The following is a description of a gene set: from publication Chaussabel D, Semnani RT, McDowell MA, Sacks D, Sher A, Nutman TB (PMID 12663451) studied in species Homo sapiens Human Gene Set: GSE360_L_MAJOR_VS_T_GONDII_MAC_DN Monocyte-derived dendritic cells (DC) and macrophages (MΦ) generated in vitro from the same individual blood donors were exposed to five different pathogens, and gene expression profiles were assessed by microarray analysis. Responses to Mycobacterium tuberculosis and to phylogenetically distinct protozoan (Leishmania major, L. donovani, Toxoplasma gondii) and helminth (Brugia malayi) parasites were examined, each of which produces chronic infections in humans yet vary considerably in the nature of the immune responses they trigger. Genes down-regulated in comparison of macrophages exposed to L. major versus macrophages exposed to T. gondii., and this is the list of marker genes: FAM8A1, IMPDH2, TFAP4, NDUFS6, PAICS, IMP4, LPAR2, MSH6, MED13L, LAS1L, GABBR2 (gamma-aminobutyric acid type B receptor subunit 2), ACP1, EEF1AKMT3, RUSC1, POM121, HDDC2 (NCBI Gene Id 51020), RUVBL1, PBX2, PIAS4, IGHM, EIF3B, ARHGEF16, FADS2, ZNF629, COQ2, HMGA1, SRRM1, APRT, RASSF1, HSF2, DOK5, KIAA0513, APEX1, LRRFIP1, CIAPIN1, RAE1, NCL, MAGEA4, DGAT1, EFNB3, CYC1, DLG2, PSMA7, IGFBP4, CHAF1A, EGR4, PARP3, PCDHB11, IQSEC2, SPINK4, FLRT1, HLX, STS (steroid sulfatase), NDUFB8, RCN2, ATP5F1D, ABL1, PLS3, COLEC10, CLASP1, MEP1B, TARBP2, TSPYL5, KIFC1, CLASRP, DKC1, ARFIP2, HS2ST1, CEACAM7, ERI3, GPR15, PLK4, NR2C1, FUT1, CNPPD1, SF3A2 (splicing factor 3a subunit 2), YES1 (NCBI Gene Id 7525, YES proto-oncogene 1, Src family tyrosine kinase), PCNA, SHMT1, NREP, IGF2BP3, IDH2, CTNNB1, GAST, SLBP, ARFGAP2, CZIB, DHCR7, GRIN1, ZNF124, H4C2, RAMP2, TRAPPC12 (NCBI Gene Id 51112), SH3YL1, LSM4, MDN1, ITPA, PIN1, ARR3, DRG1, INPP5A, POLR3C, CILK1, PTPRCAP, FAM13A, OVOL3, BRD3 (bromodomain containing 3), EI24, HMCES, FAM131A, METAP1, HRAS, DNPH1, PMS1, ECI1, PSPH, INPP4B, EXOSC7, XCL1, APOBEC3C, SDHB, ADGRF5, ADSS2, MUC6, PRMT3, PIEZO1, MCM2, SLC43A1, TCF3, DLEC1, H2AZ1, PADI2, MCM6, HOMER1, CRYAA, SGTA, NBL1, BMP1, PDE4A (phosphodiesterase 4A), GZMM, CCNE2, GPR183, CPNE1, ALG3, TYMS (NCBI Gene Id 7298), CCNB1, KBTBD11, MYO16, EPRS1, SH2B1, FOS, ATP5MC1, UPF1, MCM7, BYSL, MGAT1, BAG5, ALX1, SRSF5 (NCBI Gene Id 6430), NOLC1, PYGM, EGR3, PMPCB, SLC2A1, SLC46A3, KALRN, RRAS2, NCOR2, ILF3, PRDX2, MSH2, SRM, GLIPR1, SERPINH1, SSTR4 (NCBI Gene Id 6754), OAT, MFN2, MRPL12, HNRNPR, MGRN1, RFC4, AMHR2, HARS1, F5, IDH3B, PATZ1, TECPR2, SF3B3, CYFIP2, RNF126, ZBED4, FLAD1, RPA2, IMPA2, ASMTL, TRRAP, ZFC3H1, ATXN3, NFRKB